Given this list of marker genes PAX2, AGTR2, BASP1, ADIPOQ, RET, WT1, here is a description of the gene set: species: Homo sapiens Human Gene Set: GOBP_REGULATION_OF_METANEPHROS_DEVELOPMENT Any process that modulates the rate, frequency or extent of metanephros development. Metanephros development is the process whose specific outcome is the progression of the metanephros over time, from its formation to the mature structure. The metanephros is an endocrine and metabolic organ that filters the blood and excretes the end products of body metabolism in the form of urine.